Given this list of marker genes TUBB2A, ADAMTS3 (NCBI Gene Id 9508), ZBTB17, OBSL1, CRIP2, AUH, MSMB, PSMA6, RNFT2, ETS2, MT1G (NCBI Gene Id 84785), HRC, FGFR2, ALDH1B1, ZC3H4, LTBP4, ISLR, SELENBP1, FAM131B, TFPI, SLC31A2, TBC1D4, MAP2K3, EHD1, CHST7, TJP1, LY75, NPIPB15, SLC5A2, FAM13C, CAPN11 (NCBI Gene Id 11131), CFLAR, TRAF1, SFTPC (surfactant protein C), TM7SF2, MT1E, OPTN, ADAM8, YKT6, GHRH, ATXN2L, RYR2 (NCBI Gene Id 6262), SLC39A8, PLEKHB1, BID, NCKIPSD, RRAGB, WNT10B, NAMPT, BTG1, N4BP1, NFKBIE, CD83, ZRSR2, MMP9, MAP4K2, CCL3, PMP22, DDIT4, AKR1B1, WNT2B, B9D1, CXCR4, MT1B, EZH2, CSF2RB, PPBPP2, BICD1, CST7, GRB2, GSTO1, UNC5B, PRRG1, HHLA1, LTK, MRPL28 (NCBI Gene Id 95365), RELA, NQO2, NINJ1, ASTN1 (NCBI Gene Id 460), CETN2, KIF2A, KCNJ8, ETV6, SPINT2, SLC4A8, ISG15, SLC22A4, GPS2, TNIP1, TXN, TBC1D8, MGLL (monoglyceride lipase), SOD2, FILIP1L, RND3 (NCBI Gene Id 390), P4HA1, PAX9, PGM1, RNF19B, GEM, ENO2, ALDH1A2, BAAT, ARC (NCBI Gene Id 53837), HLX, NBN, MT2A, ENTPD2, NR2F6, INSIG2, GADD45G, SLC2A3, KCNA3, CELF2, HTR1B, INHBA, GREM1, LITAF, RGL1, ZFP36L1, INPP5F, DUSP5, FSCN1, LYPD3, IER3, FKBP1B, CXCL8, G0S2, TRAF3, ARHGEF4, CCL5, TYMP, ITSN1, KDM6B, SRPX, ZSWIM8, TNFAIP3, ELK1, GBE1, OLR1, DPP4, CYB5A, CASP5, CDYL, DOCK4, MAGEB2 (NCBI Gene Id 8234), DLGAP4, ACO1, TFRC, PI3, CHI3L1, PRKCG, PARVB, CTSL, SIKE1, IL2RG, ANGPT1, ABCC10 (ATP binding cassette subfamily C member 10), CCL8, INSM1, SYN1, POLR1F, GPR20, MARCKSL1, MGAT4C, MMP11, RAB33A, UGP2, RALB, CRHR2, EIF1AX, URB2, ADM, GNAI3, SLC11A1, TNFAIP6, MISP, AK4 (adenylate kinase 4), NDRG1, EPOR, TSG101, TRIP10, FOXO3, H1-0 (H1.0 linker histone), GADD45B, NECTIN2, RALA, EMP3, IRF7, SELL, ARL4C, CNIH3, NFKB1, CCL23, BIRC3, RASL10A, PPP1R16B, here is a description of the gene set: Genes up-regulated in comparison of dendritic cells (DC) exposed to L. donovani versus DCs exposed to 5 worm/well B. malayi. Monocyte-derived dendritic cells (DC) and macrophages (MΦ) generated in vitro from the same individual blood donors were exposed to five different pathogens, and gene expression profiles were assessed by microarray analysis. Responses to Mycobacterium tuberculosis and to phylogenetically distinct protozoan (Leishmania major, L. donovani, Toxoplasma gondii) and helminth (Brugia malayi) parasites were examined, each of which produces chronic infections in humans yet vary considerably in the nature of the immune responses they trigger. from publication Chaussabel D, Semnani RT, McDowell MA, Sacks D, Sher A, Nutman TB (PMID 12663451) Human Gene Set: GSE360_L_DONOVANI_VS_B_MALAYI_LOW_DOSE_DC_UP studied in species Homo sapiens